The following is a description of a gene set: studied in species Mus musculus The chemical reactions and pathways resulting in the formation of acetyl-CoA from pyruvate. Mouse Gene Set: GOBP_PYRUVATE_DECARBOXYLATION_TO_ACETYL_COA, and this is the list of marker genes: Dlat, Pdk2, Mpc2, Pdk1, Pdhx, Pdk3, Pdha1, Vdac1 (voltage-dependent anion channel 1), Mpc1 (mitochondrial pyruvate carrier 1), Pdhb, Pdha2, Pgk1, Dld, Pdk4, Tpk1, Bckdk